The following is a description of a gene set: Human Gene Set: GOCC_SEX_CHROMOSOME A chromosome involved in sex determination. species: Homo sapiens, and this is the list of marker genes: PHC1, SMARCB1, PLK4, UBE2B, SMC6, MACROH2A1, SPDYA, H2AX, PCGF3, SMARCC1, BIRC2, BRCA1, PCGF5, H3-3B (H3.3 histone B), RING1, LRIF1, PBX4, SUMO1, SMC5, PCGF2, H2AZ1, MAEL, HNRNPU, FIRRE, RNF2, DNMT3A, H3-3A, MACROH2A2, SUZ12, ESCO2, DMRTC2, XIST, SMCHD1, CDK2, EED, HSF5, SIN3B